The following is a description of a gene set: studied in species Homo sapiens Human Gene Set: KEGG_MEDICUS_VARIANT_MUTATION_ACTIVATED_EGFR_TO_PI3K_SIGNALING_PATHWAY Pathway Definition from KEGG: EGFR* -> PI3K -> PIP3 -> AKT -| BAD Mutation-activated EGFR to PI3K signaling pathway. Pathway ID: N00036. Pathway type: Variant. Pathway class: nt06266 Non-small cell lung cancer., and this is the list of marker genes: BAD, AKT1, AKT2, PIK3CB, AKT3, PIK3CA, EGFR, PIK3CD